The following is a description of a gene set: The aggregation and bonding together of a set of components to form a focal adhesion, a complex of intracellular signaling and structural proteins that provides a structural link between the internal actin cytoskeleton and the ECM, and also function as a locus of signal transduction activity. species: Mus musculus Mouse Gene Set: GOBP_FOCAL_ADHESION_ASSEMBLY, and this is the list of marker genes: Map4k4, Col16a1, Tsc1, Slk, Enpp2, Ptpra, Clasp1, Iqgap1, Ptk2b, Vcl, Rac1, Mmp14, Dusp3, Myh9, Ston1, Bcr (BCR activator of RhoGEF and GTPase), Fermt2, Arhgap6, Dapk3, Wdpcp, Epb41l5, Pten (NCBI Gene Id 70161), Ldb1, Phldb2, Cdh11, Sdc4, Taok2, Coro2b, Ppm1f, Ptprk, Pdpk1, Peak1, Dmtn, Bcl2, Cttn, Abl1, Dlc1, Itgav, Grem1, Coro1c, Thsd1, Myoc, Whamm, Pip5k1a, Rock1, Itga2, Gpm6b, Acvrl1, Epha3, Camsap3, Itgb1bp1, Actn2, Lrp1, Actn3, Fam107a, Nrp1, Ptpn11, Ptk2, Limch1, Rhpn1, Hrg, Macf1, Pxn, Thy1, Vegfa, Lims1, Wnt4, Efna5, Dusp22, Actg1, Src, Tek, S100a10, Apod, Kdr, Cfl1, Rcc2 (regulator of chromosome condensation 2), Sorbs1, Ajuba, Smad3, Clasp2, Actn1, Tesk2, Ptprj, Poldip2, Fmn1, Rhod